The following is a description of a gene set: studied in species Mus musculus The series of molecular signals initiated by a the C-X-C chemokine type 4 receptor on the surface of a cell binding to one of it's physiological ligands, and ending with the regulation of a downstream cellular process, e.g. transcription. Mouse Gene Set: GOBP_C_X_C_CHEMOKINE_RECEPTOR_CXCR4_SIGNALING_PATHWAY, and this is the list of marker genes: Cxcr4, Trem2, Entrep1, Lyn, Wbp1l, Cxcl12